Given this list of marker genes Rhod, Ptpro, Clasp2, Myo9a, Cldn34b1, Tbcd, Oxt, Cldn34c6, Pkp1, Amigo1, Slitrk1, Epha3 (NCBI Gene Id 353311), Crk, Peak1, Abi2, Nrxn2, Lin7c, Aplnr, Bhlhb9, Elfn1, Cntnap2, Gabra5, Wnt3a, Mmp14, Cdh7, Gabrg2, Itgav, Kdr, Gpm6a, Plxnb2, Ache, Mycbp2, Hapln4, Actn1, Slitrk6, Pdpk1, Cav1, Rps6, Hopx, Cldn11, Rac1, Prickle2, Adgrl4, Slitrk3, Fam107a, Limch1, Asic1 (acid-sensing ion channel 1), Flrt2, App, Cdh24, Slc25a46, Lin7b, Lrfn1, Prickle1, Ston1, Nrp1, Dlc1, Micall2, Irx3, Cldn15, Ugt8a, Pik3r1, Srf, Actb, Lin7a, Lingo4, Crmp1, Erbb4, Samt4 (spermatogenesis associated multipass transmembrane protein 4), Slitrk5, Cldn34d, Shank2, Itga2 (integrin alpha 2), Mapt, Ramp2, Vmp1, Mef2c, Itgb3 (NCBI Gene Id 268495), Actn2, Prkch, Pdcd6ip, Fgfr1, Tpbg, Cldn10, Vstm5, Dlg5, Sdk2, Agrn, L1cam, Ace2, Lats1, Itgb4, Lzts3, Dlg1, Lingo2, Cdh5, Kirrel3, Dclk1, Cldn8, Lrrn3, Frmpd2 (FERM and PDZ domain containing 2), Gabra3, Podxl, Sigmar1, Cbln1, Chrnb2, Gja10, Srcin1, Gabre, Myoc, Adgrb2, Nectin3, Akap5, Crb3, Dst, Capza1, Grem1, Sdk1, Rab17, Musk, Nrxn3, Clstn3, Mpdz, Cdh10, Gabrg3, Nrg3, Ube2v2, Cdhr18, Epb41l5, Ptk2, Mdga1, Cdh2, St8sia2, Six1, Gjd3, Ikbkb, Lsr, Lrfn3, Amigo3, Dbnl, Fmn1, Pkn2, Plxna1, Prkaca, Lrtm2, Npas4, Fer, Pard3, Lrrn1, Dsg3, Nr1h4, Ildr1, Zdhhc8, Zdhhc12, Large1, Actr3, Iqsec2, Cldn4, Jup, Itgb1bp1, Camsap3, Wnt7a, Cdh9, Cldn3, Fscn1, Nlgn4l, Dock7, Caskin1, Zfp703, Gabra6, Elavl2, Cldn24, Cdh4, Ghrl, Wnt11, Adgrb3, Kcnj8, Robo1, Lamc1, Cd9, Tbx5, Slc39a9, Tek, Plec, Phldb2, Il1b, Tesk2, Marveld3, Magi2, Lrfn5, Cc2d1a, Dapk3, Mpp7, Afdn (afadin, adherens junction formation factor), Bcl2, Cux2 (NCBI Gene Id 73417), Col17a1, Lrp1, Il1rapl2 (interleukin 1 receptor accessory protein-like 2), Lrrtm1, Ocel1 (NCBI Gene Id 77090), Cldn34b4, C1ql3, Cbln4, Arf6, Coro1c, Src, Cript, Ntng2, Hdac7, Prkca, Gdf2, Samt3, Sdc4, Crtac1, Zdhhc2, Gnpat, Adgre5, Cdh26, Pkp2, Cldn9, Aloxe3, Gja1, Tlr2, Neurl1a, Pum2, Fermt2, Map1b, Ptpn1, Srgap2 (NCBI Gene Id 98351), Actn3, Wdr1, Tns1, Srgap3, S100a10, Nphp1, Snap25, Plxnd1, Wnt4, Ptprk, Gabrb2, Agt, Eif4g1, Cldn14, Gap43, Gjb2, Cldn18, Cdh1, Vldlr, Dock10, Ptprj, Clstn2, Ephb1, Trpv4, Fn1, Cdh18, Cdh12 (cadherin 12), Dock4, Cldn5, Cldn34c3, Lrrc24, Drd2, Rab13, Cdh22, Nlgn3, Pxn, Rap2a, Lrrc4b, Cldn6, Plxna4, Apod, Lzts1, Marveld2, Thbs2, Dcx, Ctnnb1, Arhgap6, Bdnf, Il1rapl1, Dvl1, Cfl1, Farp1, Nfasc, Abi3bp, Capza1b, Nptx1, Cldn17, Ocln, Grm6, Lrtm1, Epha2 (Eph receptor A2), Slit2, Snca, Cacna1a, Cldn13, Cldn34b3, Lims1, Hipk1, Trim47, Map4k4, Gabra1, Elmo1, Adgrf1, Carmil3, Cdh8, Caprin1, Nrg1, Epb41l3, Nedd4l, Cldn34b2, Ldb1, Rac3, Nptn, Lrp4, Cdh17, Plxnc1 (NCBI Gene Id 80638), Hrg, Cdh3, Cldn34c2, Ppm1f, Vegfa, Ube2m, Il1rap, Ephb2, Lhfpl4, Efnb1, Ntrk3, Dusp22, Gpbar1, Cdh20 (cadherin 20), Ntrk2, Col16a1, Eef2k, Cdk5, Actn4, Bcr, Fbxo45, Numb, Rtn4r, Cldn19, Add2, Reln, Pip5k1a, Ogt (O-linked N-acetylglucosamine (GlcNAc) transferase (UDP-N-acetylglucosamine:polypeptide-N-acetylglucosaminyl transferase)), Bsn, S1pr2 (NCBI Gene Id 68430), Lrrtm3, Gabra2, Rapgef1, C1ql2, Vps35, Thy1 (thymus cell antigen 1, theta), Cgn, Adgrl1, Pten, Nckipsd, Chd4, Ect2, 2610042L04Rik, Ptpn11, Srpx2, Gria1, Gpc4, Cdh6, Dnm3 (dynamin 3), Rapgef2, Gabra4, Plxna3, Samt1d, Abi3, Dusp3, Pof1b, Cdh15, Gjc1, Nae1, Myo1c, Enpp2, Igsf11, Lrfn4, Sh3bp1, Dlg4, Efna5, Sptbn2, Lama3, Smad7, Adgrl3, Setd5, Mdga2, Dkk1, Ube3b, Ptprs (protein tyrosine phosphatase receptor type S), Ptpn13, Epha7, Pclo, Nrxn1, Abl1, Clasp1 (NCBI Gene Id 76707), Actg1, Xlr3b, Flrt1, Lgi2, Cntn5, Acvrl1, Dmtn (NCBI Gene Id 13829), Slk, Dscam, Rtn4, Adnp, Slitrk2, Cldn34a, Prkcz2, Cldn2, Sema4c, Slit1, Negr1, Fkrp, Ptk2b, Arhgef15, Cldn16, Crkl, Numbl, Cntnap1, Gpm6b, Rhoc, Rock2, Samt2b, Stau2, Esam, Rcc2, Jam3, Ephb3, Efnb3, Gjb6, Rhpn1, Arhgap33, Sema4a, Tjp1, Sorbs1, Myh9, Nlgn1, Gabrb3, Clstn1, Oxtr, Adgrl2, Patj, Efnb2, Wnt5a, Icam5, Sipa1l1, Ppp1r9b, Rap1b, Six4, Itga5, Wdpcp, Rhog, Dock1, Itgb1, Nedd8, Mark1, Usp9x, Tsc1, Cldn34c1, Myo6, Il17a, Slc12a5, Nlgn2, Grid2 (NCBI Gene Id 94324), Poldip2, Nptxr, Pcdh17, Sema4d, Pak2, Rhoa, Ophn1, Pkp3, Snai2, Samt1b, Cdc42, Arl2, Rock1, Ctnna1, Fgf13, Ntn1, Fzd1, Slitrk4, Ptprd, Lrrtm4, Gabrg1, Rab29 (NCBI Gene Id 226422), Ghsr, Cldn22, Shank3, Taok2, Csmd2 (CUB and Sushi multiple domains 2), Flot1, Coro2b, Cadm1, Plxnb1, Sdcbp, Macf1, Lrit3, Tnf, Pecam1, Htr4, Nphp4, Cldn7, Iqgap1, Vcl, Gna13, Cdh19, Rap1a (RAS-related protein 1a), Gsk3b, Cldn1 (claudin 1), Cdh11, Plxnb3, Mecp2, Plxna2, Iqsec1, Cldn12, Snai1, Asic2, Ppp1r9a, Rps6-ps4, Nphs1, Arhgef9, Flrt3, Pmp22, Tln1, Flcn, Alox12b, Whamm, Cpeb3, Pdgfb, Pdlim5, Ace, Cldn23 (claudin 23), F11r (F11 receptor), Colq, Grin1, Ajuba, Amigo2, Syndig1, Pdzd11, Cyfip2, Lrrtm2, Lrrc4, Gja5, Thsd1, Ptpra, Fbf1, Ntrk1, Nrg2, Pkp4 (NCBI Gene Id 67756), Grhl2, Cttn, Cdh13, Cldn34c4, Cldn34c5, Cbln2, Fzd5, Samt2, Psd, Smad3, Adgrb1, Nectin1, here is a description of the gene set: Mouse Gene Set: GOBP_CELL_JUNCTION_ASSEMBLY studied in species Mus musculus A cellular process that results in the aggregation, arrangement and bonding together of a set of components to form a cell junction.